Given this list of marker genes NOTCH1, ZIC3, NOTCH2, CITED2, EPB41L5, IFT172, PKD1L1, SETDB2, ARL13B, PITX2, SMO, IFT25, MNS1, DLL1, here is a description of the gene set: Human Gene Set: GOBP_LEFT_RIGHT_AXIS_SPECIFICATION studied in species Homo sapiens The establishment, maintenance and elaboration of the left/right axis. The left/right axis is defined by a line that runs orthogonal to both the anterior/posterior and dorsal/ventral axes. Each side is defined from the viewpoint of the organism rather of the observer (as per anatomical axes).